Given this list of marker genes Plg, Mapk14 (NCBI Gene Id 26416), Bmp4 (bone morphogenetic protein 4), Ang, Dhcr7, here is a description of the gene set: studied in species Mus musculus The von Hippel-Lindau tumor suppressor pVHL regulates the stability of hypoxia-inducible factors (HIF)-1 and -2, oxygen-sensitive basic helix-loop-helix transcription factors, which mediate the hypoxic induction of angiogenic growth factors such as vascular endothelial growth factor. Loss of pVHL function results in constitutive activation of HIF-1 and HIF-2 and is associated with the development of highly vascularized tumors in multiple organs. We have used a conditional gene-targeting approach to investigate the relative contributions of HIF-1 and HIF-2 to VHL-associated vascular tumorigenesis in a mouse model of liver hemangiomas. Here we demonstrate genetically that conditional inactivation of HIF-2alpha suppressed the development of VHL-associated liver hemangiomas and that angiogenic gene expression in hepatocytes is predominantly regulated by HIF-2 and not by HIF-1. These findings suggest that HIF-2 is the dominant HIF in the pathogenesis of VHL-associated vascular tumors and that pharmacologic targeting of HIF-2 may be an effective strategy for their treatment. from publication Rankin EB, Rha J, Unger TL, Wu CH, Shutt HP, Johnson RS, Simon MC, Keith B, Haase VH (PMID 18490920) Angiogenic genes up-regulated in hepatocytes after knockout of VHL and HIF2A. Mouse Gene Set: RANKIN_ANGIOGENIC_TARGETS_OF_VHL_HIF2A_UP